The following is a description of a gene set: The directed movement of some substance from inside of a cell, across the plasma membrane and into the extracellular region. Mouse Gene Set: GOBP_EXPORT_ACROSS_PLASMA_MEMBRANE species: Mus musculus, and this is the list of marker genes: Kcnip1, Atp1a2, Heph, Fxyd3, Atp1a1, Kcne4, Slc30a10, Slc40a1, Slc47a1, Slc8a1, Ywhae, Agrn, Kcnq1, Calm2, Kcnn4, Fxyd7, Atp1a3, Kcnh2, Atp1b2, Gja1, Kcne3 (potassium voltage-gated channel, Isk-related subfamily, gene 3), Nppa, Ralbp1, Slc8a3 (NCBI Gene Id 20543), Slc22a18, Abcc5, Wnk4, Kcnb1, Tmem163, Ano6, Atp1b1, Kcne2, Atp1b3, Slc30a1, Kcnip2, Fxyd2, Slc22a2, Atp12a, Slc9a1, Slc47a2, Slc27a1, Fxyd5, Kcna5, Slc17a3, Atp4b, Slc8a2, Atp2b1, Dlg1, Fxyd6, Hamp, Kcne1, Slc29a4, Abcc1, Slc38a5, Kcnt2, Slc24a4, Atp1a4, Hamp2, Kcne5, Abcg2, Slc30a2, Oscp1, Abca1, Atp2b3, Rgs9, Fxyd4, Slc36a2, Abcb1a, Abcc4, Fxyd1, Kcna2, Abcb1b, Slc4a4, Abcc2, Kcnd3, Slc30a4, Atp4a, Kcnk18, Slc35g1